Given this list of marker genes ASPSCR1, UPF2, TEF, METTL27, CLN6, ANKMY2, SH3BP5, RSAD2, ZNF667, SNHG8, CSRNP1, PPP1R1B, MIDEAS, CCDC91, IQSEC1, FASN, HACD3, MTR, PLCG1, CNOT6L, C11orf68, RASGRP1, NFKBIZ, AGBL5, FUCA2, NAF1, MIGA1, RCL1, PEX2, MRPS34, CORO2B, ARID5B, EPS8L1, ST8SIA6, C11orf71, MAP2K5 (NCBI Gene Id 5607, mitogen-activated protein kinase kinase 5), LGI1, EZH1, DYNLT3, ST3GAL1 (ST3 beta-galactoside alpha-2,3-sialyltransferase 1), FDXR, LDHB, RAF1, GPR155, CERS6, IFFO2, PITPNM2, SESTD1, DGKA, PADI1, DENND11, ELOVL5, ECHDC1, MRPL36, RNF19A, TMEM18, AKT1S1, E2F5, PEX3, TCN2, CASP6, WDFY1, TNP2, METTL3, NINJ1, TNC, ZFP36L1, LRRIQ3, LTB, ZNF672, TEFM, FAM234B, CORO1B (coronin 1B), RAB2B, RPS21, PENK, MGARP, PTPRE, TDRP, SMYD4, NLK, NUMA1, STX16, RAP1GAP, GLG1, MBTPS2, ACTG2, CTDNEP1, CFAP418, ENTPD6, PINK1, CDKAL1 (CDK5 regulatory subunit associated protein 1 like 1), FDX1, TBX6, SUCO, MSI2, BPHL, GNL1, HSD17B11, C22orf39, ACOT11, JARID2, FMNL3, SKAP1, RTL8C, GRAMD1B, CRB3, RCSD1, TMEM106C, TARS2, IFT140, JAK2, POLD4, TLCD1, MBOAT7, MTSS1, VMAC, RDH12, DHX34, PLA2G2C, COG5 (component of oligomeric golgi complex 5), CCDC102A, RALGAPA1, RGMB (repulsive guidance molecule BMP co-receptor b), PER1, CXCL10, OAS1, ZNF436 (NCBI Gene Id 80818), DDX24, ANKRD10 (ankyrin repeat domain 10), YPEL3, PDLIM7, TTLL12, LYL1, TMEM245, SNX13, ALKBH1, NUDT14, NOCT, PRXL2B, EIF2B2, SMIM20, MEX3B, IKBIP, NARS2, PNPLA6, FAU, SFMBT2, N4BP2, CCDC62, DECR2, TMEM191C, KIF5C, NHLRC1, PTPN9, CLK2, ZNF446, EDC3, PIGX, RNF149, SIAE, DPP4, TMEM230, INPP5K, UBAC2, ZNF48, DNAH8, XPOT, BRSK2, DTD1, CNP, PPCDC, ACSF2, AGPAT5, INAFM1, SCP2, DCAF11, TRIM25, ANKH, CBR1, KLHL7, TCF12, RFESD, RAB3GAP2 (RAB3 GTPase activating non-catalytic protein subunit 2), HMG20A, EARS2, SLC25A1, RCOR3, XXYLT1, AREL1, IL27RA, IFT80, PDCD1LG2, RNF128, TFCP2, EGR3, SAV1, ECSIT, MIA2, DAG1, here is a description of the gene set: Genes down-regulated in double positive thymocytes from: B6 versus NOD mice. Human Gene Set: GSE2128_C57BL6_VS_NOD_CD4CD8_DP_THYMOCYTE_DN from publication Zucchelli S, Holler P, Yamagata T, Roy M, Benoist C, Mathis D (PMID 15780994) species: Homo sapiens Fetal thymic organ culture (FTOC) DC2.5 CD4+CD8+ thymocytes from B6g7 or NOD background. 0 or 16 hour after addition of the BDC mimitope